The following is a description of a gene set: Mouse Gene Set: GOBP_MONOACYLGLYCEROL_BIOSYNTHETIC_PROCESS The chemical reactions and pathways resulting in the formation of monoacylglycerol, any ester of glycerol in which any one of its hydroxyl groups has been acylated with a fatty acid, the other being non-esterified. species: Mus musculus, and this is the list of marker genes: Awat2, Dgat1, Dgat2l6, Mogat2, Dagla, Daglb, Pla2g4a, Dgat2